The following is a description of a gene set: studied in species Homo sapiens Genes up-regulated in bone marrow-derived dendritic cellstreated by poly(IC): 0h versus 12h. Human Gene Set: GSE21033_CTRL_VS_POLYIC_STIM_DC_12H_UP BACKGROUND: Dendritic cells (DC) play a central role in primary immune responses and become potent stimulators of the adaptive immune response after undergoing the critical process of maturation. Understanding the dynamics of DC maturation would provide key insights into this important process. Time course microarray experiments can provide unique insights into DC maturation dynamics. Replicate experiments are necessary to address the issues of experimental and biological variability. Statistical methods and averaging are often used to identify significant signals. Here a novel strategy for filtering of replicate time course microarray data, which identifies consistent signals between the replicates, is presented and applied to a DC time course microarray experiment. RESULTS: The temporal dynamics of DC maturation were studied by stimulating DC with poly(I:C) and following gene expression at 5 time points from 1 to 24 hours. The novel filtering strategy uses standard statistical and fold change techniques, along with the consistency of replicate temporal profiles, to identify those differentially expressed genes that were consistent in two biological replicate experiments. To address the issue of cluster reproducibility a consensus clustering method, which identifies clusters of genes whose expression varies consistently between replicates, was also developed and applied. Analysis of the resulting clusters revealed many known and novel characteristics of DC maturation, such as the up-regulation of specific immune response pathways. Intriguingly, more genes were down-regulated than up-regulated. Results identify a more comprehensive program of down-regulation, including many genes involved in protein synthesis, metabolism, and housekeeping needed for maintenance of cellular integrity and metabolism. CONCLUSIONS: The new filtering strategy emphasizes the importance of consistent and reproducible results when analyzing microarray data and utilizes consistency between replicate experiments as a criterion in both feature selection and clustering, without averaging or otherwise combining replicate data. Observation of a significant down-regulation program during DC maturation indicates that DC are preparing for cell death and provides a path to better understand the process. This new filtering strategy can be adapted for use in analyzing other large-scale time course data sets with replicates. from publication Olex AL, Hiltbold EM, Leng X, Fetrow JS (PMID 20682054), and this is the list of marker genes: PCBD2, TNFAIP1, NIN (NCBI Gene Id 57681), IL18RAP, B2M, PAQR7, MYO1F, NT5M, SH2D1A, GPR18, TES, RPS6KA1, CRACR2A, NPC2, IL12RB2, ISYNA1, FAM169BP, PECAM1, RPLP0, RPA1, N4BP2L1, PITPNC1, LTB (NCBI Gene Id 4050), SMAP2, SHISA5, GPRC5B, STK17B, UBE2E2, ABHD11, RASSF3, ANO10, UTRN, TRIB2, SH3BP5, TRIAP1, EZH1 (enhancer of zeste 1 polycomb repressive complex 2 subunit), NIPAL1, DSE, VKORC1, STRIP2, HERPUD1, CIB1, GPR65, RIGI, GIMAP7, NDUFA10, EBPL, ITM2B, KLHL3, DYRK2, SRPK1, TMA7, ADAMTS10, LCP1, RPS2, GRIA3, RPL22, RRAS2, IL7R, DTX1, TMEM59, MED22, VIM, S1PR4, CCR4, MFSD1, TSPAN14, SUCLG2, TRMT1 (tRNA methyltransferase 1), SNX5, MPP7, CARD6, BAIAP3, FOXO1, SCAPER, MRRF, STARD5, CALCRL, CPQ, P2RX4 (NCBI Gene Id 5025), ALDOA, RPS26, TMEM185A, MYO1G, CYP20A1, IFT22, NRAS, RUNDC3B, ITGB3, ART4, SNORD87, IRAK4, HMGCS1, C19orf38, CYTH4, RPLP1, TPM4, LY9, DPH5, TNFRSF14, GNG2 (G protein subunit gamma 2), DPM2, MGAT2, HIGD2A, INPP5F, APRT, UBASH3A (ubiquitin associated and SH3 domain containing A), RAB23, UBAC2, ELOVL7, CDH18, SLFN5, IKZF2, TMTC4, SLC20A1, ZBTB9, CNN2, CPM, TPST2, HEXB (hexosaminidase subunit beta), DIPK1A, GIMAP6, EYA2, CDK2AP2, SESN1, CUEDC1, RAPGEF4, GBP2 (NCBI Gene Id 2634), CD48, XPOT, MPV17, EEF2K, JAK1, MLEC, FLNA, SLC16A6, ANKMY2, PYHIN1, ABCB8, SLC66A3, PVT1, USP24, KLF8, SELL, PTPN22, FAM3C, RIPOR2, SNAP47, TLE4, AFDN, CD226, FGD3, TSPAN32 (tetraspanin 32), ANXA6, SLC35G1, CYRIA, FLI1, IFNGR2, AGFG1